Given this list of marker genes Isca2, Hscb, Glrx5, Fdx1, Iscu, Lyrm4, Isca1, Nfs1, Fdxr, Fdx2, Fxn, here is a description of the gene set: species: Mus musculus Mouse Gene Set: REACTOME_MITOCHONDRIAL_IRON_SULFUR_CLUSTER_BIOGENESIS Mitochondrial iron-sulfur cluster biogenesis